Given this list of marker genes Rnf31, Rbck1, Sharpin, Xiap, Prkn, here is a description of the gene set: A protein ubiquitination process in which a linear polymer of ubiquitin, formed by the amino-terminal methionine (M1) of one ubiquitin molecule and by the carboxy-terminal glycine (G76) of the next, is added to a protein. species: Mus musculus Mouse Gene Set: GOBP_PROTEIN_LINEAR_POLYUBIQUITINATION